Given this list of marker genes NTNG1, RTL9, POU2F2, FAM131B-AS1, SLC17A6-DT, PCDH10-DT, OPRM1, LINC00951, OPRK1, RN7SKP76, ERC2, NPTXR, here is a description of the gene set: from publication Cao J, O'Day DR, Pliner HA, Kingsley PD, Deng M, Daza RM, Zager MA, Aldinger KA, Blecher-Gonen R, Zhang F, Spielmann M, Palis J, Doherty D, Steemers FJ, Glass IA, Trapnell C, Shendure J (PMID 33184181) The gene expression program underlying the specification of human cell types is of fundamental interest. The study authors generated human cell atlases of gene expression and chromatin accessibility in fetal tissues. For gene expression, the study authors applied three-level combinatorial indexing to >110 samples representing 15 organs, ultimately profiling ~4 million single cells. The study authors leveraged the literature and other atlases to identify and annotate hundreds of cell types and subtypes, both within and across tissues. Our analyses focused on organ-specific specializations of broadly distributed cell types (such as blood, endothelial, and epithelial), sites of fetal erythropoiesis (which notably included the adrenal gland), and integration with mouse developmental atlases (such as conserved specification of blood cells). These data represent a rich resource for the exploration of in vivo human gene expression in diverse tissues and cell types. Marker genes curated from the annotated cluster as represented in the Descartes Human Gene Expression During Development database. species: Homo sapiens Human Gene Set: DESCARTES_MAIN_FETAL_LIMBIC_SYSTEM_NEURONS